The following is a description of a gene set: part of: Sphingolipid metabolism Reactome Pathway: Sphingolipid catabolism studied in species Homo sapiens The main steps involved in de novo sphingolipid synthesis are annotated here., and this is the list of marker genes: ALDH3B2, SGPL1, ALDH3B1, ACER1, ACER2, PLPP3 (phospholipid phosphatase 3), ALDH3A2, SGPP2, PLPP1, PLPP2, ACER3, SGPP1